The following is a description of a gene set: Mouse Gene Set: GOBP_SPHINGOID_BIOSYNTHETIC_PROCESS species: Mus musculus The chemical reactions and pathways resulting in the formation of sphingoids, any of a class of compounds comprising sphinganine and its homologues and stereoisomers, and derivatives of these compounds., and this is the list of marker genes: Asah2, Sptlc1, Acer1, Gba1, Abca2, Sptlc3, Sphk1, Sptssb, Acer2, Acer3, Sptssa, Agk, Sphk2, Sptlc2, Asah1